Given this list of marker genes CTNNB1, NF1, NSUN2, MSX2 (NCBI Gene Id 8053), SPINK5, GAL, TGFB2, TRPC4AP, FERMT1, WNT10B, RBPJ, WNT5A, NOM1, CDH3, ERCC2, here is a description of the gene set: Human Gene Set: GOBP_HAIR_FOLLICLE_MATURATION species: Homo sapiens A developmental process, independent of morphogenetic (shape) change, that is required for a hair follicle to attain its fully functional state.